Given this list of marker genes NGDN, TOX3, TNFSF8, BTBD7, POMGNT1, PATL1, MCL1, TMEM50B, SLC6A17, CAP1, BPNT1, E2F7, SDC3, FBXO28, UBQLNL, PRX, DHRS13, PUS10, ERGIC2, ACOT8, RSF1, ENTPD5, KY, SYNRG, FAM98C, STK17B, PMS1, ARF4, TKT, AGPS, RAB6B, ZSWIM5, CD93, ORAI2, STRA6, CMTR1, LLCFC1 (LLLL and CFNLAS motif containing 1), MAP4K2, RGS4, BEAN1, S100A7A (S100 calcium binding protein A7A), ARIH1, AHNAK, GPC6, SETD7, GALNT15, CCDC88A, TSPYL6, MFAP3, RHOG, IL22RA1, RNF4, LINC03043, KLHL12, EPGN, UGT2B7, GLI2, SIRPG, COPZ1, CRTC1, TMEM267, NFYA, PRR3, CCDC107, SV2B, ATF7IP2, ZNF592, DNAJB9, NTRK3, SLC2A1, CHAD, IRAK3, FBN1, PID1, BTN2A2, CEP72, MTUS1, EML6, DPP8, SERAC1, PLA2G5, AHCY (adenosylhomocysteinase), C1orf210, CDH19, NCAPH, ZKSCAN4, NFAT5, TMEM201, AFG1L, AP3S1, UNC5D, DAZAP1, TMEM191C, DNM1, INTS14, IST1, FNIP1, AFAP1L2, SLC23A2, TUB, NRARP, COLQ, ROCK2, CECR2, ADK, SLC29A3, ZNF860, TAFA5, DMRT2, MB21D2, F2RL2, RAB9B, ASB8, PURA, RET, KCNB1, PI4KB, TMEM191B, SGMS2, PDP2, FAHD2B, ZBTB20, NCR3, KCNU1, RFC3, LRRC61, COL6A5, STEAP2, RELCH, RIDA, PGM3, PPP2R5E, NAA20, PNMA2, LRRC20, LCK, PUS7, PIGA, TCTA, ELL3, CASTOR2, CAMLG, B4GALNT1, PCDHB5, GUCY2C, CSMD3, DCAF10, THOC2, FAAP24, SARM1 (NCBI Gene Id 23098), AKAP12, RPS3A, ARL14, MTMR4, PSIP1 (NCBI Gene Id 93428), here is a description of the gene set: Genes predicted to be targets of miRBase v22 microRNA hsa-miR-3664-3p in miRDB v6.0 with MirTarget v4 prediction scores > 80 (high confidence targets). species: Homo sapiens Human Gene Set: MIR3664_3P from publication Chen Y, Wang X (PMID 31504780)